Given this list of marker genes PLP2, TNFRSF11A, LMNA, LAIR1, PPP1R15A, ICOSLG, GEM, ATP5PO (ATP synthase peripheral stalk subunit OSCP), HYOU1, EZR, ENG (endoglin), YWHAH, CXCL8 (NCBI Gene Id 3576), PPIF, NCOR2 (NCBI Gene Id 9612), CCL3, CSRP1, ENO2, S100A9, FADS2, SORL1, CDC42EP4, MARCKSL1, MAPKAPK2, CLUH, SLC16A3, MRC1, AGO2, HMGA1, TPD52L2, HPCAL1, CLIC1, PLEKHO2, SSR4, LGALS1, RPN2, VAPB, PTX3, THBD, BID, CRIP1 (NCBI Gene Id 1396), RAB35, UAP1, RPL10A (NCBI Gene Id 4736), CCL4, XBP1, RXRA, C1orf216, FABP5, THBS1, PEMT, PSMD1, PHLDA2, ARL4C, TNFAIP3, ADA, CXCL2, POLG, ARL4A, SERPINE1, SLC4A7, RHOG, SLC7A5, TBX10 (NCBI Gene Id 6912), HSPA1A, GET3, TRAF1, CDC37, TUBB2A, SERPINB8, PI4K2A, TNFSF8, HNRNPA3, CD4, IER3, FLRT2, NQO1, CSF2RA, PSMD11, LHFPL2, PPM1F, EMP3, EMP1, ALCAM, MEF2A, GNA15, ELK4, FOSB, RBM14, EEF1B2, TULP3, EIF3K, SMAD6, MSC, AMPD3, HOMER3, EIF4A1, TMEM41B, TNIP1, CCL7, PLOD3, ITGB5, CALM1, ANPEP, FYN, NDUFB8, CAPN2, TNFSF14, SRSF2, COMT, ZMYND11, SLC4A2, IL1B, BIN1, MIR22HG, G0S2, TXNRD1, ZNF3, KBTBD2, F13A1, NFKB1, DDIT4, S100A4, BCAP31, BRD2, PLCG1, HNRNPL, GPR183 (G protein-coupled receptor 183), LIMS1 (LIM zinc finger domain containing 1), MMD, DPYSL3, PNP, CRK, SLC35A2 (solute carrier family 35 member A2), MPHOSPH6, SFXN3, KANK1, AATK, INPP1, CD99, EEF1G, MN1, DNAJB5, PHLDB1, UQCRQ, SMS, PEA15, ENC1, ZBTB43, PCBD1, DNMBP, SHB, YWHAZ, ATP9A, MATK, STK38L, ACTR1A, CD180, CKAP4, SDF2, EEF1D, NDUFS6, ZW10, ORAI2, SH3BP5, EBP, DUSP2, ANXA3, PLEC, STAB1, GAS2L1, PLAUR, SH3GL1, TUBB4A, USP14, PPARG, UPP1, SRF, TGFBI, NPM3, CYP1A1, RAB9A, PDXK, OLR1, FUS, RPL36A, S100A8, TIPARP, DUSP1, PLTP, ATF3, KRT10, ITPA, SMURF2, CD163, PLIN2, SERPINB2, DHCR7, RPS4Y1, CD83, here is a description of the gene set: Human Gene Set: GSE22196_HEALTHY_VS_OBESE_MOUSE_SKIN_GAMMADELTA_TCELL_DN Epithelial cells provide an initial line of defense against damage and pathogens in barrier tissues such as the skin; however this balance is disrupted in obesity and metabolic disease. Skin gamma delta T cells recognize epithelial damage and release cytokines and growth factors that facilitate wound repair. To determine the impact of obesity and metabolic disease on skin gamma delta T cells, we isolated skin gamma delta T cells from 10-week old C57BLKS/J lean db/+ and obese db/db animals for further study. Due to a deficiency in the leptin receptor (db), homozygous db/db animals do not process satiety signals, continually eat and develop severe obesity and metabolic disease. Skin gamma delta T cells isolated from these animals were compared for changes in mRNA expression using microarray. We have determined that obesity and metabolic disease negatively impacts homeostasis and functionality of skin gamma delta T cells, rendering host defense mechanisms vulnerable to injury and infection. Genes down-regulated in skin gamma delta T cells: healthy versus obesity. studied in species Homo sapiens from publication Taylor KR, Mills RE, Costanzo AE, Jameson JM (PMID 20625397)